Given this list of marker genes FBXL7, ZNF205, CRISP2, CIMAP1B, LRP8, HS2ST1, MTM1, DDX19A (NCBI Gene Id 55308), FAM222A, H2AX, PCNT, SULF1, ADD2, DAP3, CLRN3, MRI1, ADSL, UBASH3A, PPP5C, AP1B1, SNHG6, TNXB, KNTC1, AGBL5, TIPIN, LDB1, ELN (elastin), HRAS, KCTD20, CLPX, PDYN, DIAPH3, COPS3, PHTF1, SRRT, HSPE1, PRNP, HELQ, ZNF771, SETD6, SAE1, NUP93, PSMC5, MGME1, SGO2, TRIM13, RCOR3, MATCAP2, SRRM1, COPRS, OR10AD1, MYBPC1, MIER2, CLNS1A, CENPH, LRRC42, DYRK3, FTMT, ESRRG, MPHOSPH6, WRAP53, TMT1B, FARSA (NCBI Gene Id 2193), USP54, TUBB1, METTL13, ZDHHC13, DCAF1, SUCLG1, MLLT1, CDK1, PNO1, PWP1 (PWP1 homolog, endonuclein), STRBP, NOP10, RLIG1 (RNA 5'-phosphate and 3'-OH ligase 1), ATP5F1A, GPSM2, GARS1, WNT10B, BMP1, PES1 (pescadillo ribosomal biogenesis factor 1), NOL8, SGCE, ZC3H14, LCMT2, PCLAF, SLC4A10, CCDC34, PSMG2, TXN2, LANCL2 (NCBI Gene Id 95548), PDGFD, MINDY1, CREB3L2, MGMT, ATP1A2, SYCP2, DMAC2L, FIRRM, BHMT2, G3BP1, NUP155, CDX4, BACE2, SCRN3, TCEAL1, EIF4E, SKP1, EIF3L, HSPD1, NOB1, FBF1, VWC2, SMPD4, INTS9, MFSD4A, CLYBL, VRK1, MRPL42, FRRS1, CEP72, SIRT4, CDH7, LRRC28, NAA10 (NCBI Gene Id 8260), LRP12, EIF2B5, FASN, FOXRED2, DTX4, UROC1, BDH1, ACSL3, AP1AR, PPP1R36 (NCBI Gene Id 145376), SFTPA1, ME3, NENF, TPM2, PRODH, SAT2, YRDC, RRP15, NOP56, DIO2, SPSB1, RPRD1B, NKD2, MFSD13A, NUDT12, NOP16, SUV39H1, SCG3, IARS2, EIF3G, SORBS3, CCDC150, C8orf48, HADH, SLC6A13, TIMM8B, ARHGAP21, HCN3, MRPL48, GP5, ANGPTL4, RHOBTB1, FASTKD5, DNAAF10, MORC2, GSDMC, CFAP418, KICS2, PAX7, SLC7A6, RHD, PDXP, SALL3, AP2A1, ANP32B, SLC30A10, RIMKLA, SEC61A2, BLVRB, PSMB2, SLC28A3, PECR, TIMM9, SMARCA5, IPO4, HDHD2, FBXW10, TCEAL9, PITHD1, TEFM, CCNF, TOPBP1, TBRG1, ADI1, here is a description of the gene set: from publication Konuma T, Nakamura S, Miyagi S, Negishi M, Chiba T, Oguro H, Yuan J, Mochizuki-Kashio M, Ichikawa H, Miyoshi H, Vidal M, Iwama A (PMID 21540074) Each fraction of mouse hematopoietic cells was purified by cell sorting from bone marrow of 8-week-old C57BL/6 mice, and its gene expression was analyzed. species: Homo sapiens Genes up-regulated in comparison of lineage negative versus NK cells. Human Gene Set: GSE27786_LIN_NEG_VS_NKCELL_UP